Given this list of marker genes Ftcd, Carnmt1, Carns1, Hal, Uroc1, Amdhd1, here is a description of the gene set: Reactome Pathway: Histidine catabolism This event has been computationally inferred from an event that has been demonstrated in another species.<p>The inference is based on the homology mapping from PANTHER. Briefly, reactions for which all involved PhysicalEntities (in input, output and catalyst) have a mapped orthologue/paralogue (for complexes at least 75% of components must have a mapping) are inferred to the other species. part of: Metabolism of amino acids and derivatives species: Mus musculus electronically inferred by orthology from the curated human pathway